The following is a description of a gene set: The process in which calcium salts, mainly carbonated hydroxyapatite, are deposited into the initial acellular cementum. studied in species Mus musculus Mouse Gene Set: GOBP_CEMENTUM_MINERALIZATION, and this is the list of marker genes: Alpl, Wls, Enpp1, Sp7, Ank, Hacd1, Fgfr1